Given this list of marker genes CLCN6, SLC12A7 (NCBI Gene Id 26129), STX7, SLC4A7, SGK1, CLCNKA, CLCN7, GABRA5, SLC4A2, FXYD1, GABRG3, BEST2, STX1A, SLC6A12, ANO9, CLCC1, CLDN17, GPR89B, SLC4A1, SLC6A2, TTYH3, SLC12A1, GABRA2, SLC6A8 (solute carrier family 6 member 8), SLC26A9, SLC17A8, BEST1, VTI1B, SHOC2 (SHOC2 leucine rich repeat scaffold protein), ANO7, SLC4A5, CLIC3, GABRA4, CLCN5, ANO1, GABRR1 (gamma-aminobutyric acid type A receptor subunit rho1), GABRG1, AQP6, GABRE, GABRR3, SLC6A18, PACC1, DCD, GABRB3 (gamma-aminobutyric acid type A receptor subunit beta3), LRRC8E, SLC4A3, SLC12A3, ANO10, GABRA1, SLC4A10, VDAC1, TTYH1, ANO8, CLCNKB, SLC26A1, CLCA1, CLCA2, CLIC4, SLC1A2, SLC17A6, SLC5A6, SLC22A1, CLIC5, C8orf44-SGK3, SLC26A3, CLIC1, SLC25A27, SLC12A9, GABRA6, GABRA3, SLC18A1, SGK3, SLC12A5, GABRR2, TMC4, SLC12A8, ANO4, SLC26A7, SLC26A4, UCP2, SLC12A2, SLC5A8, GLRB, APOL1, CCT8L2, SLC6A3, GLRA1, SLC5A5, SLC1A4, SLC26A10P, NHERF1, SLC4A4, SLC12A6, CLCN2, SLC26A6, CLCA4, CFTR, OCA2, SLC13A1, GABRB2, GABRP, LRRC8C, SLC6A13, SLC6A11, GABRB1, SLC6A1, ANO5, CLIC2, FXYD3, NMUR2, SLC12A4, ANO6, P2RX5, SLC26A2, GPR89A, SLC1A1, ANO2, CLIC6, ANO3, BSND, GLRA3 (NCBI Gene Id 8001), VDAC3, SLC39A14, SLC18A2, LRRC8D, GABRG2, MCOLN3, VDAC2, GABRQ, SLC19A1, SLC26A11, TTYH2, VAMP8, PANX1, SLC1A7, CLDN4, CLCN1, SLC26A8, SLC6A4, MCOLN1, BEST3, GABRD, SLC4A8, SLC17A3, SLC25A14, LRRC8B, SLC17A7, CLCN3, SLC6A6, BEST4, SLC26A5, LRRC8A, MFSD8, GLRA2, CHRNA7, CLCN4, STX8, SLC4A9, here is a description of the gene set: Human Gene Set: GOMF_MONOATOMIC_ANION_TRANSMEMBRANE_TRANSPORTER_ACTIVITY species: Homo sapiens Enables the transfer of a negatively charged ion from one side of a membrane to the other.